The following is a description of a gene set: The morphological and physiological alterations undergone by mitochondria during apoptosis. Human Gene Set: GOBP_APOPTOTIC_MITOCHONDRIAL_CHANGES studied in species Homo sapiens, and this is the list of marker genes: AIFM2, DNM1L, GCLC, BOK, BCL2L2, EYA2, CHCHD10, MTCH2, ATP2A1, ATG3, PYCARD, IFI6, BCL2L11, GSK3A, PINK1, TMEM14A, SIVA1, ACAA2, GHITM, HRK, PLSCR3, PSMD10, GPER1, MUL1, FAM162A, IFIT2, NOL3, BCL2L1, BAK1, PPIF, PRELID1, MLLT11, PMAIP1, BAX, FXN, BID, LMNA, GPX1, MIR17, VDAC2, STPG1, TMEM102, SLC25A31, AKT1, NPTX1, PRKN, GGCT (gamma-glutamylcyclotransferase), NAIF1, MOAP1, SOD2, RTL10, CAMK2A, THEM4 (NCBI Gene Id 117145), CCAR2, LRRK2, HK2, GSK3B, SLC25A5, BMF, HIGD1A, ATP7A, RHOT2, TP53, SMAD3, BAD, HIP1R, MIR29A, SLC35F6, HSPA1A, ZNF205, BNIP3, BCL2A1, FMC1, DAP3, BCL2L10 (BCL2 like 10), PLAUR (NCBI Gene Id 5329), HSPD1, ATF2, TIMM50, MIR29B1, OPA1, BBC3, MMP9, ATP5IF1, IGF1, JTB, BNIP3L, TRIAP1, SFN, VPS35 (NCBI Gene Id 91808), PARL, BIK, TNFSF10, PPM1K, RHOT1, IER3, BLOC1S2, HGF, ERBB4, GCLM, BCL2, FZD9, FIS1, MPV17L, SLC25A6, MCL1, PPP2CB, MIR29C, SLC25A4, TP73, CLU, PIM2